Given this list of marker genes PMP22, ST3GAL5, ACOX1, MT-TE, SPTAN1, GDAP1, RUBCN, RYR1, HSPB1, ATP6AP2, here is a description of the gene set: Human Gene Set: HP_HYPOREFLEXIA_OF_UPPER_LIMBS studied in species Homo sapiens Reduced intensity of muscle tendon reflexes in the upper limbs. Reflexes are elicited by stretching the tendon of a muscle, e.g., by tapping. Hyporeflexia of upper limbs